The following is a description of a gene set: Genes predicted to be targets of miRBase v22 microRNA mmu_miR_7652_3p in miRDB v6.0 with MirTarget v4 prediction scores > 80 (high confidence targets). from publication Chen Y, Wang X (PMID 31504780) Mouse Gene Set: MIR_7652_3P species: Mus musculus, and this is the list of marker genes: Sft2d3, Vash1, Pde1a, Crabp2, Steep1, Pten, Btbd3 (NCBI Gene Id 228662), Vstm5, Cacng6, Abce1, Tgfb2, Sae1, Tia1, Praf2, Suclg2, Trabd2b, Shb, Zfp772, Lifr, Pou6f1, Lims1, Tnrc18, Jade2, Csf2ra, Fkbp1b, Stc1, Ccdc97, Tmc3, Aff1, Cand1, Wwtr1, Fbrs, Kansl1l, Csgalnact2, Carmil1, Cxcl12, Hcar2, Smim14, Aff3, Zbed3, Adamts3, Zfp7, Pea15a, Arhgap21, Mgll, Mia3, Fam124b, Derl2, Kctd17, Spin1, Klhl23 (kelch-like 23), Hmox2, Cnih4, Hapstr1, Zfp12, Ints3, Entpd7, Niban1, Kctd10, Smim15, Atrn, Sfmbt2, Eif4b, Ptafr, Prss53, Pdzph1, Nrp2, Kcnb1, Primpol, Mmaa, Kazn, Fam210b, Ccr4, Lgals1, Prmt8, Slc7a2 (solute carrier family 7 (cationic amino acid transporter, y+ system), member 2), Pgf, Cdkl4, Kcnn3, Prkab1, Zfp329, Cacna1s, Appl2, Plag1, Trps1, Syt7, Tnrc6b, Pml, Atg16l2, Lrtm2, Kcnab1, Slc16a10, Adcy1, Fmn2, Dync1i1, Ska1, Patz1, Fam136a, Nrg4, Kank2 (NCBI Gene Id 260376), Nr4a3, Tcerg1 (NCBI Gene Id 76839), Mdm2, Sertad2, Amotl2, Fahd1, Cdk19, Ipo8, Slc4a4, Tmbim1, Zfp428, Reps2, Gask1a, Rnf20, Slc26a5, Aak1 (NCBI Gene Id 97341), Mtfr1, Uvssa, Kbtbd4, Mpig6b, Rcan2, Rab1a, Lrrc32, Casr, Tln2, B4galnt2, Pde3a, Pmm2, Poc5, Zim1